The following is a description of a gene set: species: Mus musculus Mouse Gene Set: GOBP_KETONE_METABOLIC_PROCESS The chemical reactions and pathways involving any of a class of organic compounds that contain the carbonyl group, CO, and in which the carbonyl group is bonded only to carbon atoms, as carried out by individual cells. The general formula for a ketone is RCOR, where R and R are alkyl or aryl groups., and this is the list of marker genes: Akr1c14, Coq8b, Twist1, Coq8a, Prmt3, Kyat3, Ggcx, Slc45a3, Akr1c21, Coq4, Aifm2, Ces1f, Sirt6, Malrd1, Ins2, Ankrd26, Slc22a13, C1qtnf2, Ido1, Ces1h, Gprc6a, Cyp46a1, Ceacam1, Adh4, Dgat2, Tdo2, Rdh16, Cyp7a1, Wnt4, Pdss2, Nr1h3, Ndufa9, Acacb, Ces1e, Insig2, Ces1c, Cbr4, Hnf4a, Haghl, Gatd1, Coq7, Ptgs2, Vkorc1l1, Inhba, Cyp2b13, Nr1d1, Egr1, Brca1, Afp, Pnkd, Prkag2, Coq6, Etfbkmt, Prox1, Bglap, Apoc2l, Apoa4, Rdh9, Hsd17b6, Srebf1, Acsl4, Rdh16f2, Cyp11b1, Apoc2 (NCBI Gene Id 11813), Fgf15, Hsd3b8, Abcb11, Ghsr, Pgk1, Pla2g3, Ces1g, Akr1cl, Nr1h2 (nuclear receptor subfamily 1, group H, member 2), Apoc1, Obp2a, Cav1, Prkg1, Kdsr, Afmid (arylformamidase), Insig1, Fmo1, Pparg, Rest, Dgkq, Irs1, Akr1c12, Nmt1, Ednrb, Nqo1, Kat2b, Glo1, Fabp5, Avp, Eif6, Tysnd1 (trypsin domain containing 1), Apoc3, Elovl5, H6pd, Erfe, Akr1c20, Ubiad1, Mlycd, Park7, Abcd1, Sirt2, Apoa5, Nucb2, Aldh8a1, Oxct1, Sox9, Hsd17b10, Coq3, Vkorc1, Acadl, Pdss1, Adipoq, Scp2, Cyp2b10, Mlxipl, Akr1c6, Pdk3, Srd5a2, Hsd17b1, Cd74, Ncor2, Rdh10, Fmo2, Hsd3b4, Mir199a-2, Klhl25, Sirt4, Cbr1b, Adck2, Gk, Sirt1, Dab2, Hmgcr, Creb1, Clcn2, Ppard, Akt1 (NCBI Gene Id 268604), Pptc7, Dhrs4, Cbr1, Abcd2, Bglap2, Cyp11b2, Hsd11b2, Ido2, Mid1ip1, Kcnma1, Mapk9, Wdtc1, Akr1b1, Snca, Eif2ak3, Mtln, Lpgat1, Bmp5, Tpk1, Ces1a, Hsd3b9, Pdk4, Rdh1, Akr1a1, Nqo2, Ppara, Fgfr4, Dgat1, Aadat, Avpr1a, Erlin2, Trex1, Stard4, Coq5, Ppargc1a, Erlin1, Pibf1, Lonp2, Bmp6, Hagh, Acsl5 (acyl-CoA synthetase long-chain family member 5), Ins1, Nfe2l1, Ceacam2, Plin5, Gip, Cacna1h, Rdh19, Akt2, Irs2, Dhrs9 (NCBI Gene Id 241452), Anxa1, Kynu, Akr1c19, Mtor, Il1b, Trib3 (NCBI Gene Id 23913), Kyat1, Dcaf5, Cyp2b19, Fabp1, Fmo4, Hsd17b3, Acadvl, Fabp3, Cyp17a1, Kmo (NCBI Gene Id 98256), Cyp2b23, Srd5a1, Dkkl1, Pdk2, Mfsd2a (NCBI Gene Id 76574), Ncor1, Ces1b, Akr1c18, Mir214, Stard3, Agt, Coq9, Hsd3b5, Aldoa, Scnn1b, Star, Scap, Cyp19a1 (cytochrome P450, family 19, subfamily a, polypeptide 1), Dkk3, Cpt1a, Cyp21a1, Ces1d, Pla2g4a, Rgn (regucalcin), Cmtm2a, Cyp11a1, Pank2, Gdf15, Tpi1, Bckdk, Cyp2b9, Ubr4, Pdk1, Bmp2, Sirt5, Cyp4f40, Cnr1, Rtn4ip1, Appl2, Dbi, Cbr3, Akr1c13, Stat5b, Coq2